The following is a description of a gene set: Catalysis of the transfer of an amino group to an acceptor, usually a 2-oxo acid. studied in species Mus musculus Mouse Gene Set: GOMF_TRANSAMINASE_ACTIVITY, and this is the list of marker genes: Phykpl, Amt, Got2, Psat1, Gpt, Agxt, Aadat, Oat, Abat, Gfpt2, Agxt2, Bcat1, Etnppl, Accs, Mgat4a, Tat, Gfpt1, Accsl, Bcat2, Tgm2, Kyat1, Got1l1, Kyat3, Got1, Cisd1, Gpt2 (NCBI Gene Id 98512)